The following is a description of a gene set: Splicing of RNA via recognition of the folded RNA structure that brings the 5' and 3' splice sites into proximity and cleavage of the RNA at both the 3' and 5' splice sites by an endonucleolytic mechanism, followed by ligation of the exons. species: Mus musculus Mouse Gene Set: GOBP_RNA_SPLICING_VIA_ENDONUCLEOLYTIC_CLEAVAGE_AND_LIGATION, and this is the list of marker genes: Zbtb8os, Ddx1, Tsen2, Clp1, Tsen54, Ern1, Rtcb, Tsen15, Tsen34, Rtraf, Trpt1